The following is a description of a gene set: Genes positively differentially expressed in cell type: Macrophage upon treatment with cytokine: IL-31 in mouse lymph nodes in vivo. from publication Cui A, Huang T, Li S, Ma A, Pérez JL, Sander C, Keskin DB, Wu CJ, Fraenkel E, Hacohen N (PMID 38057668) Cytokines mediate cell-cell communication in the immune system and represent important therapeutic targets. A myriad of studies have highlighted their central role in immune function, yet we lack a global view of the cellular responses of each immune cell type to each cytokine. To address this gap, the authors created the Immune Dictionary, a compendium of single-cell transcriptomic profiles of more than 17 immune cell types in response to each of 86 cytokines (>1,400 cytokine-cell type combinations) in mouse lymph nodes in vivo. A cytokine-centric view of the dictionary revealed that most cytokines induce highly cell-type-specific responses. For example, the inflammatory cytokine interleukin-1β induces distinct gene programmes in almost every cell type. A cell-type-centric view of the dictionary identified more than 66 cytokine-driven cellular polarization states across immune cell types, including previously uncharacterized states such as an interleukin-18-induced polyfunctional natural killer cell state. studied in species Mus musculus Mouse Gene Set: CUI_MACROPHAGE_IL31_RESPONSE_UP, and this is the list of marker genes: Ifitm2, Tuba1c, Hck, Atp6v1b2, Ccl9, Agfg1, Txnrd1 (thioredoxin reductase 1), Ptpn1, Wfdc17, Marcks, Csrp1, Ywhag, Ube2s, Actg1, Evi2a, Clec4n, Eif4a1, Plekho2